The following is a description of a gene set: from publication Cui A, Huang T, Li S, Ma A, Pérez JL, Sander C, Keskin DB, Wu CJ, Fraenkel E, Hacohen N (PMID 38057668) studied in species Mus musculus Genes positively differentially expressed in cell type: Treg upon treatment with cytokine: TNF-α in mouse lymph nodes in vivo. Mouse Gene Set: CUI_TREG_TNFA_RESPONSE_UP Cytokines mediate cell-cell communication in the immune system and represent important therapeutic targets. A myriad of studies have highlighted their central role in immune function, yet we lack a global view of the cellular responses of each immune cell type to each cytokine. To address this gap, the authors created the Immune Dictionary, a compendium of single-cell transcriptomic profiles of more than 17 immune cell types in response to each of 86 cytokines (>1,400 cytokine-cell type combinations) in mouse lymph nodes in vivo. A cytokine-centric view of the dictionary revealed that most cytokines induce highly cell-type-specific responses. For example, the inflammatory cytokine interleukin-1β induces distinct gene programmes in almost every cell type. A cell-type-centric view of the dictionary identified more than 66 cytokine-driven cellular polarization states across immune cell types, including previously uncharacterized states such as an interleukin-18-induced polyfunctional natural killer cell state., and this is the list of marker genes: Sting1, Dennd5a, C1qtnf12, Ranbp1, Edf1, Traf1, Mpc1, Nfkbia, Nop16, Bcl2a1d, Sdc4, Il1r2, Pdap1, Map2k3, Stat5a, Nfkb1, St6galnac4, Chd4, Eif4a1, Psme2, Il21r (interleukin 21 receptor), Nfkb2, Ccr6, Actr3 (NCBI Gene Id 74117), Gsdmd, Ly6e, Mrpl21, Mxd1, Odc1, Tapbp, Tapbpl, Zfp36l2, Tnfrsf4, Dusp2, Gbp5, Itpk1, Dgat2, Ldha, Stat1, Syngr2, Pa2g4, Sik3, B2m, Hif1a, Ppa1, Myo1g, Mllt6, Bcl2l1, Ly6a, Bcl2a1b, Fas, Gramd2b, Lsm4, Psme1, Flot1, Serinc3, Slfn2, Cish, Actg1, Ppp1r16b, Batf, Hacd3, Mknk2, Snrnp40, Gadd45b, Tmem123, Med8, Tbc1d9b, Slc25a19, Isy1, Aldoa, Zmiz2, Psmb10, Tuba4a, Birc3 (NCBI Gene Id 11796), Nfkbie, Tgif1, Bhlhe40, Marcksl1, Isg15, Dennd4a, Ifngr1, Ifrd1, Gbp2, Gtpbp4, Ltb, Chrac1, Alkbh6, Aimp2, Mapkapk2, Nfkbib (nuclear factor of kappa light polypeptide gene enhancer in B cells inhibitor, beta), Dgat1, Psmb5, Vars1, Slc25a3, Cyba, Il2rb, Lmna, Hspa5, Icam1, Stat3, Gpr183, Skap2, Psmb2, Fth1, Eif5a, Stx11, H2-K1, Dnaja2, Relb, Mif4gd, Myl12b, Ctdnep1, Hspa8, Hopx, Crtc2, Mvp (major vault protein), Aebp2 (AE binding protein 2), Serpina3g, Sumo2, Nmi (NCBI Gene Id 64685), Tnfrsf18, Ptp4a2, Calr, Psma6, Id2, Pde6d, Myl12a, Apobec3, Jak2, Crem, Ppp1r14b, Ptma, Ier2, Eif6, Tnfrsf9, Sdhaf1, Cd82, Kdm2b, Wnk1, Ran, Sema4d, Nom1, Nhp2, Zbp1, H2-Q7, Tmpo, Ehd1, H2-Q4, Eny2, Bcl3, Chmp4b, Tnfaip3, Sdf4, Rpap3, G3bp1, H2az1, Pmepa1 (NCBI Gene Id 99365), Plagl2 (pleiomorphic adenoma gene-like 2), Wdr12, Gpx4